The following is a description of a gene set: Ficolins bind to repetitive carbohydrate structures on the target cell surface studied in species Homo sapiens Human Gene Set: REACTOME_FICOLINS_BIND_TO_REPETITIVE_CARBOHYDRATE_STRUCTURES_ON_THE_TARGET_CELL_SURFACE, and this is the list of marker genes: FCN3, MASP1, MASP2, FCN1, FCN2